The following is a description of a gene set: The appearance of interleukin-21 due to biosynthesis or secretion following a cellular stimulus, resulting in an increase in its intracellular or extracellular levels. studied in species Homo sapiens Human Gene Set: GOBP_INTERLEUKIN_21_PRODUCTION, and this is the list of marker genes: MIR192, IL6 (interleukin 6), MIR222, MIR21 (microRNA 21), MIR221, FOXP1, MIR215